The following is a description of a gene set: Any process that results in a change in state or activity of a cell or an organism (in terms of movement, secretion, enzyme production, gene expression, etc.) as a result of a glucagon stimulus. Human Gene Set: GOBP_RESPONSE_TO_GLUCAGON species: Homo sapiens, and this is the list of marker genes: CCNA2, PRKAR1A, FUT1 (NCBI Gene Id 2523), CYC1, CDO1, ASS1, PRKACA, CPS1, GCG, MT-CYB, GCGR, ABCB1 (NCBI Gene Id 5243), GNAS, ADCY8, GLP2R, HMGCS2, SREBF1, GLP1R, CREB1, CRY1